Given this list of marker genes RARRES2, ADIPOQ, MGST1, PLIN4, SAMM50 (NCBI Gene Id 25813), DLST, TSPAN12, QDPR (NCBI Gene Id 5860), GDF5, C9orf72, SCP2, CBR1, DECR1, SLC25A1, CMBL, BCKDHB, CCNG2, C6orf136, SUCLG1 (succinate-CoA ligase GDP/ADP-forming subunit alpha), SDHA, CIB2, ADCY6, NDUFC1, DHRS7B, BNIP3, TUFM, UQCR10, POLN, GPD1, CA3, NDUFS3, ORM2, FASN, APMAP, PNPLA2 (patatin like phospholipase domain containing 2), COQ5, NDUFB9, EHD1, ARL4A, NDUFS1, GCSH, ABCA1, ADIG, SDHB, ACYP2, FAH, LCN2, TP53INP2, COX7A2, ADISSP (NCBI Gene Id 54976), MGLL, GBE1, NDUFA5, NES, CAVIN2, HIBCH, SGCD, PRXL2A, LTC4S, AOC3, NDUFA9, DGAT1, SOWAHC, QKI, CD151, PLA2G6, CD4, UQCRC2, RBPMS, KAT2B, UNC119, NABP1, SLC2A4, HIPK2, UCK1, CAT, LPL, REEP6, ATP5PO, THRSP, PSEN2, OGDH, HP, NDUFB3, TANK, PEX19, CAMP, NOCT, MCCC1 (NCBI Gene Id 56922), GSR, NDUFB8, RETSAT, CFD, G0S2, BBLN, C11orf54, RNF11, CIDEC, CDKN2C, MAP4K4, HYCC2, RAB3D, TKT, RETN, MRAP, ITGA6, LUM, HADH, ACADL, PDHB, MC2R, ISOC1, ACADS, S100A1, TST, PON2, CYB5B, CDIP1, UQCRC1, S100A8, APOE, BCAT2, ALAD, ETFDH, APOC1, SLC19A1, WFDC12, SLC25A10, DLAT, SFXN1, HSD17B12, NDUFB2 (NADH:ubiquinone oxidoreductase subunit B2), CHPT1, ACAA1, PGM2, CS, LIAS, ISCA1, CA2, DDT, FMC1, PPP2R5A, ALAS1 (5'-aminolevulinate synthase 1), LDHB, AGPAT3, IMPDH1, HSD17B4, ACAA2, SCARB1, AQP7, C1QTNF12, TAB3, GRHPR, PLA2G12A, NDUFB6, DBT, FXN, UQCRQ, NDUFB5, MRPL51, PARM1, CYRIB, LONP2, ALDH1A1, NR1H3, ME1, NDUFB7, MPDU1, ABCD2, HSD11B1, CYB5A, COX5B, SDHC, COX7B, UQCRB, ATP5F1D, PXMP2, CD1D (NCBI Gene Id 912), OR2H2, PDAP1, ORM1, HIBADH, SOX15, PHTF2, DHCR7, DLD, DNAJC15, ACAD9, CHCHD3, COL15A1, REEP5, NNMT, here is a description of the gene set: Strongly up-regulated at 96 h during differentiation of 3T3-L1 cells (fibroblast) into adipocytes. During cellular differentiation and development, it is recognized that many complex molecular mechanisms as well as precise patterns of differentially expressed genes occur in directing precursor cells toward a given lineage. Using microarray-based technology, we examined gene expression across the course of 3T3-L1 adipocyte differentiation. Total cellular RNA was isolated at times 0, 2, 8, 16, 24, 48, and 96 h following treatment with either standard hormonal inducers of differentiation; insulin, dexamethasone, isobutylmethylxanthine (IDX), or IDX plus trichostatin A (TsA), a histone deacetylase inhibitor and potent adipogenic inhibitor. cRNA was synthesized from cellular RNA and hybridized to high density Affymetrix MG_U74Av2 microarray gene chips containing 12,488 cDNA/Expressed Sequence Tags (ESTs) probe sets. From the IDX-only treated cells, all probe sets that were either unchanged or differentially expressed less than 2-fold throughout differentiation with respect to time 0 preadipocytes were excluded from further analyses. This selection resulted in a net of 1686 transcripts, 859 were increased in expression, and 827 were decreased in expression at least 2-fold across differentiation. To focus in on genes that were more specific to differentiation, the same analysis was performed on IDX plus TsA-treated non-differentiating cells and all probe sets from the IDX-only group that exhibited similar expression profiles in the non-differentiating TsA-treated group were excluded leaving a total of 1016 transcripts that were regulated only under differentiating conditions. Six hundred and thirty-six of these transcripts were elevated at least 2-fold and 380 exhibited a decrease in expression relative to time 0 preadipocytes. This group of genes was further analyzed using hierarchical clustering and self-organizing maps and resulted in the identification of numerous genes not previously known to be regulated during adipocyte differentiation. Many of these genes may well represent novel adipogenic mediators and markers of adipogenesis. species: Mus musculus Human Gene Set: BURTON_ADIPOGENESIS_6 from publication Burton GR, Nagarajan R, Peterson CA, McGehee RE Jr (PMID 15033539)